Given this list of marker genes NFKBIA, EHD1, TREM2, PPARG, C3, VSTM2A, PNPLA2 (NCBI Gene Id 57104), PLIN5, ALKBH7, CRP, PPARD, PTPN2, CD36, PPARA, PLIN3, ZC3H12A, FTO, TNF, HILPDA, ITGB3, MEST (NCBI Gene Id 95680), MIR144, LPL, CPT1A, NR1H3, ACACB, ITGAV, MIR10B, SREBF2, TTC39B, IKBKE, APOB, IL6, PLA2G10, PLIN2, ABCA1, NFKB1, NR1H2, SCARB1, MIR34A, MIR146A, CES1, LEP, FBXW7, MSR1, SIRT1, CLSTN3, SREBF1, ABHD5, APOC4, ABCG1, here is a description of the gene set: studied in species Homo sapiens Human Gene Set: GOBP_REGULATION_OF_LIPID_STORAGE Any process that modulates the rate, frequency or extent of lipid storage. Lipid storage is the accumulation and maintenance in cells or tissues of lipids, compounds soluble in organic solvents but insoluble or sparingly soluble in aqueous solvents. Lipid reserves can be accumulated during early developmental stages for mobilization and utilization at later stages of development.